The following is a description of a gene set: Human Gene Set: WP_INTERLEUKIN1_INDUCED_ACTIVATION_OF_NFKB studied in species Homo sapiens Interleukin-1 induced activation of NF-kB, and this is the list of marker genes: UBE2V1, TRAF6, TIFA, SQSTM1, IRAK1, NFKB1, AJUBA, IL1A, UBE2N, PRKCZ